The following is a description of a gene set: Mouse Gene Set: MIR_3473B_MIR_3473E Genes predicted to be targets of miRBase v22 microRNA mmu_miR_3473b, mmu_miR_3473e in miRDB v6.0 with MirTarget v4 prediction scores > 80 (high confidence targets). studied in species Mus musculus from publication Chen Y, Wang X (PMID 31504780), and this is the list of marker genes: Ccdc149, Mnt, Hectd1, Srgap1, Pate3 (NCBI Gene Id 100312956), Syt1, Il10ra, Srf, Lamc2, Hdlbp, Kprp, Rnf43, Radil, Clock, Slc1a1, St6galnac6, Plin4, Nedd9, Nbea, Scn9a, Xpo7, Sfrp5 (secreted frizzled-related sequence protein 5), Pdk2, Ctla2b, Psd2, Lysmd1, Bptf, Mapk9, Pappa2, Il7 (interleukin 7), Psd3, Wsb2, Igsf8, Gsg1l, H2-Q7, Rere, Supt7l, Tmed8, Rab11fip1, Zfp626, Plp2, Dnajc27, Ube2ql1, Sarm1, Cxcl16, Adcy1, Susd6, Hoxb1, Lingo4, C1qtnf6, Car7, Adpgk, Rbpms, Aldh6a1, Faf1, Tmem248, Rspry1, Xbp1, Ndst1, Tst, Ascc2, Apoe, Rmi2, Fam170b, Gpr37, Adgrf4, Aak1, Micos10, Abt1, Rasgrp1, Zfp827, Dnajc8, Tafazzin, Cdh11, Znrf3, Otop2, Mrps21, Nacc2, Tpcn1, Hecw1, Spag11b, Cplx2, Efnb3, Gli2, Mpeg1, Yju2b (YJU2 splicing factor homolog B), Pitpnb, Plec (plectin), Il36g, Cbfa2t3, Mpzl2, Plekhm3, Gnb5, Bltp3a, Itgam, N4bp1, Map6d1, Ephb2, Runx3, Ddah1, Ptprf, Shroom4, Zdhhc7